Given this list of marker genes LILRB1, MYEF2 (myelin expression factor 2), SNAI1, MEIS2, KCNQ1, ADGRD1, KCNH5, SPRED3, AUTS2, CLDN8, C18orf32, PRCC, GRM6, SPSB1, DNAAF8 (dynein axonemal assembly factor 8), BHLHE40, STC1, GRN (NCBI Gene Id 2896), DUXA, ADAMTS14, WFDC12, GLIS3, IL27RA, CAMK2N2, ABI3, RPL17-C18orf32, HTR4, ADGRF4, P2RY2, PRDM7, C12orf76, FAM174B, NTF4, APC2, CLIP3, TUBB4A, ETS1 (NCBI Gene Id 2113), CSRP1, here is a description of the gene set: Genes predicted to be targets of miRBase v22 microRNA hsa-miR-615-5p in miRDB v6.0 with MirTarget v4 prediction scores > 80 (high confidence targets). studied in species Homo sapiens from publication Chen Y, Wang X (PMID 31504780) Human Gene Set: MIR615_5P